Given this list of marker genes Alkal1, Gm10568, Gm5694, Gm37108, Oprk1, Gm19002, Lypla1, Gm19026, Nras-ps2, Gm19938, Gm7470, Gm26901, Gm15452 (predicted gene 15452), Xkr4, Gm19214, Gm26206, St18, Gm26983, Gm37323, Rgs20, Rp1, Rb1cc1 (NCBI Gene Id 77109), Gm6104, Sox17, Gm1992, Gm6101, Gm7182, Atp6v1h, Tcea1, Gm30414, Pcmtd1, Mrpl15, Gm7369, Gm27396, Npbwr1, Gm7341, Gm16041, 4933401J01Rik, Gm6119 (NCBI Gene Id 636569), Gm17101, Rps2-ps2, Gm18956, Gm7449, Gm23274, Gm18984, Gm2053, Gm2147, Gm6123, Gm7417, Gm9826, Gm7357, 4732440D04Rik, Gm6085, here is a description of the gene set: species: Mus musculus Mouse Gene Set: chr1A1